The following is a description of a gene set: from publication Baram D, Dekel O, Mekori YA, Sagi-Eisenberg R (PMID 20190146) species: Homo sapiens Human Gene Set: GSE19888_ADENOSINE_A3R_INH_VS_ACT_WITH_INHIBITOR_PRETREATMENT_IN_MAST_CELL_DN We demonstrate that the G protein Gi3 is the cellular target of the adenosine A3 receptor (A3R). By using a cell permeable peptide comprising the C-terminal end of Gαi3 fused to an importation sequence (ALL1) as a selective inhibitor of Gi3 signaling, we show that by coupling to Gi3, the A3R stimulates multiple signaling pathways in human mast cells, leading to upregulation of cytokines, chemokines and growth factors.Following contact with activated T cell membranes, endogenous adenosine binds to and activates the A3R, resulting in Gi3-mediated signaling. Specifically, the majority of ERK1/2 signaling initiated by contact with activated T cell membranes, is mediated by Gi3, giving rise to ALL1-inhibitable cellular responses. These results unveil the physiological GPCR that couples to Gi3 and establish the important role played by this G-protein in inflammatory conditions that involve adenosine-activated mast cells. We used microarrays to detail the effect of ALL1 on gene expression of HMC-1 cells activated directly by the A3 receptor, or by contact with activated T cell membranes. Genes down-regulated in HMC-1 (mast leukemia) cells incubated the peptide ALL1 versus those followed by treatment with Cl-IB-MECA., and this is the list of marker genes: LBX2, CACNG1, PVALB, H2BC5, IL1RL1, BHLHE41, POMGNT1, QSOX1, EGLN2, TRPC6, TRAF3IP3, LPIN3, CACNA1S, GTF2I, UQCRQ (ubiquinol-cytochrome c reductase complex III subunit VII), B3GNT8, ARHGEF25, SFTPA1, MGMT, RRP9, TMEM151B, REM1, MCRIP2, TNNI1, FBXO31, HMGB3, SLIT3, DPEP1, LAMA5, WNT11, CKAP5, SLC4A3, ADCY10, COL14A1, HSD17B6, GORASP1, PGAP3, PLCD3, FAM53B, RAMP1, INMT, BORCS5 (BLOC-1 related complex subunit 5), TTLL12, GPR88, GIPC3, ATXN7L2, PGM1, PNKD, AKAP12, PARP1, ESM1, SCN10A, STC1, ARHGEF17 (NCBI Gene Id 9828), HAAO, ROM1, PPP2R5A, BIN1, LBX1, DRD3, C19orf44, TSFM, SLC5A11, RING1, TRPC4AP, SLC37A4, PRUNE1, SLC4A4, DELE1, CLSTN3, DMWD, TEKTL1, AAMDC, DENND6A, KLC2, ACTC1, GPC6, PKM, GUK1, ITGA2B, FTH1, TMPRSS3, ALDOA, CEBPA (NCBI Gene Id 1050), CFAP410, CHRND, CA5B, SDK1, NAV1, DOHH, CDC34, PLA2G6, AGPAT2, CA8, NUDT3, PPP1R3B, CTNNBIP1, CNMD, HSD17B3, CCDC65 (coiled-coil domain containing 65), HSBP1, AMPD1, PRM3, CALY, ERAS, GPD1, FSCN3, C16orf96, FN1, CC2D2B, TNNI2, COPS7A, ITM2A, LRFN3, CDC42BPB, C1QL3, TBXT, GPR6 (NCBI Gene Id 2830), KLHL13, PODXL, MIP, ABCF3, BET1L, CDHR5, TSPAN3, ARL2, GAL, CHCHD5 (coiled-coil-helix-coiled-coil-helix domain containing 5), PLPP7, GPT, PIDD1, POLD4, GMPR, PDGFRA, DES, RANBP17, FOXA3, MDGA1, PATL2, ADRM1, MARCHF4, RAB4B, ZEB2, SLC26A6, VSIR, IFT46, MLEC, SEC16B, IER2, OSR1, CYSTM1, FNDC1, HDAC4, ASZ1, SCGB3A1 (NCBI Gene Id 92304), RBFA, SYCP2, SH2D6 (SH2 domain containing 6), LY6H, CLCN2, SH2B2, THEM6 (thioesterase superfamily member 6), EYA2, SLC25A1, ACTN3, PDLIM7, TRAF4, MRPL28, CD83, KCNH2, SPOCK2, KCNB1, PABPC4, NOVA1, ANKRD23, RNF133, PYGM, EDNRB, MYOZ1, APOA1, KIAA1614, CLEC4M, DEFB116, VTN, TBC1D21, CKM, USP5, MATN4, TMEM100, BACE1, CHCT1, MYBPH, FGFR1, NKAIN4, DAPK1, TNNC1, JPH2, PLPPR2, TSPAN13, MINDY4